Given this list of marker genes Itsn1, Abi2, Kptn, Cttn (cortactin), Myo5a, Actg1, Actn4, Cttnbp2, Myo6, Actn2, Actb, Itpka, Myo5b, Myh10, Fam107a, Filip1, Ppp1r9a, Myo9b (NCBI Gene Id 17925), Dbn1, here is a description of the gene set: Mouse Gene Set: GOCC_POSTSYNAPTIC_ACTIN_CYTOSKELETON The actin cytoskeleton that is part of a postsynapse. species: Mus musculus